The following is a description of a gene set: Transcriptional response of murine allogeneic T cells (B10.BR) after stimulation with different organ-derived (spleen, liver, peripheral and mesenteric lymph nodes) dendritic cells (C57BL/6) in vitro studied in species Homo sapiens Genes down-regulated in allogeneic T cells after stimulation with dendritic cells from: mesenteric lymph nodes (mLN) versus spleen. Human Gene Set: GSE5503_MLN_DC_VS_SPLEEN_DC_ACTIVATED_ALLOGENIC_TCELL_DN from publication Kim TD, Terwey TH, Zakrzewski JL, Suh D, Kochman AA, Chen ME, King CG, Borsotti C, Grubin J, Smith OM, Heller G, Liu C, Murphy GF, Alpdogan O, van den Brink MR (PMID 18178870), and this is the list of marker genes: HDAC8, TIAM1, ENDOU, PRP4K, PSMD2, STRBP, PLA2G1B, SBK1, TMEM245, SGPP1, HIBCH, MCPH1, CD5, SUMF1, NUP35, RBM27, TLNRD1, ZBTB6, ILF2, VPS13D, MSN, UCP2, SLFN12, C8orf82, DDX41, THAP12, ZC3H8, MTRES1, MED10, ACTL6A, ATL2, MOB4, NKAP, BMP2K, FBXL5, PSMF1, RARS1, KRTAP20-2, ENDOD1, GCN1, PDCD1, HS3ST4, PPP1R11, SANBR, RAD51C, GPSM2, ZNF274, ST8SIA6, OXNAD1, MLH1 (mutL homolog 1), MPHOSPH9, FASTKD2, PRPF4, TRIAP1, POU2F1, GAS2L3, TMCC1, ACP5, EZH2, IGFBPL1, TIMM9, TMEM183A, YOD1, APPL1, HCRTR2, CHID1, CEP41, TMEM263, LHFPL6, MRTO4, ECSIT, CARHSP1, MLX, DBF4, PRR11, MTREX, B3GNT2, SNIP1, MUS81, ARF5, TRAPPC2, CIAO3, MRPL1, MBD2, APAF1, ANKRD37 (ankyrin repeat domain 37), TTC32, SRFBP1, YARS1, SNRNP40, HSPH1, RBM44, GRB10, AKAP1, SMTN, ARHGAP12 (NCBI Gene Id 94134), BUD23, FRYL, RAB35, RNPC3, PIK3AP1, WDR35, MAN1A2, NDUFAF4, GIN1, PDE2A, CD37, CSE1L, FOXO1, NR1D1, MTAP, AKIRIN1, PCED1B, RIF1, CNIH2, MDN1, N4BP2, CCT8, CHP1, TRAPPC8, SDC4, ORC5, RAD51AP1, ASH2L, KRAS, ATP6V1C1, HBS1L, ARMC6, SLC4A7, URB2, CENPE, CCNE2, PPIH, CLDN18, SRPK3, NABP1, SAPCD1, MLLT3, CTPS1, HDAC3, ZNF296 (zinc finger protein 296), DENND1B, DHPS, POLR2D, CCDC124, BYSL, CRIP2, CPLX2, RRAS2, MEGF9, ATG4B, YTHDC2, IPCEF1, PAIP1, PIF1, AP1AR, PLEKHA2, MLANA, LMO3, KIAA0040, FAM3C, ELAC2, ARHGAP19, BEND3, FDPS, RASL11B, IFI30, THBD, EME2, HROB (NCBI Gene Id 78995), SUV39H1, TMEM177, MYL10, CIMIP1, REEP4, PPM1G, ABCB6 (ATP binding cassette subfamily B member 6 (LAN blood group)), TMEM26, POC1A, EIF2S1, SLC22A14, PARD6A, CCDC71L, RB1, PAX5, FXR1, PREP, MYCBP, TMEM209 (NCBI Gene Id 84928), ACSS1, STK11, ATF7, ATP2A3 (NCBI Gene Id 489), EPRS1, TRAIP, POLR3B, TASP1, MTHFD2, PLEKHG2, CSNK2A1